The following is a description of a gene set: Episodes of muscle weakness. Human Gene Set: HP_PERIODIC_PARALYSIS studied in species Homo sapiens Periodic paralysis, and this is the list of marker genes: GABRA3, KCNE3, SCN4A, CDH23, FAH, KCNJ5, ABCB6 (NCBI Gene Id 541461), KCNJ2, CACNA1S, KCNJ18, CA2